Given this list of marker genes ZNF354C, MAP7D1, MORC3, TUT4, ICAM2, NFKBID, SUSD3, AGFG1, EMP3, METTL26, HARBI1, TXNDC9, SESN3, PDLIM5, CSTPP1, ARF6, ARSK, FBXO32, C6orf132, KLF10, B3GALT5, CELF1, TOR3A, RASL11A, PTPRC, PI4K2B, NUDCD1 (NudC domain containing 1), MIB2, MORC1, PRCC, NPM3 (NCBI Gene Id 63295), PLCG1, TPST2, STN1, CDC14A, MSS51, ITGA7, B3GNT2, ZNF565, FAM133B, MEF2D, PLP1, ARRDC2, BAIAP2, COX7A1, JAK1 (NCBI Gene Id 3716), YIPF7, SEPTIN6, MNAT1, UCHL1, AHI1, ZNF260, UCK1, SAMD9L, ZDHHC20, ANKRD28, GPR65, XIRP1, RIOK1, RAD52, HRH2, PLCH1, NXPE3, MOB2, PHOX2A, MXD1, PYCR2, CHL1, SURF1, OAS1, UCP1, DNAAF4, ZNF704, STIM2, VSIR (V-set immunoregulatory receptor), KLHL42, RAMP1, MAPK1, PTPRG, TIFAB, AKAP13, BST2, LIMS4, CTU1, WIPI2, TMEM242, CPNE3, SCO1, PPCDC, TMEM18, ZNF322 (zinc finger protein 322), ABHD11, CDC14B, KLF7, PAK1IP1, ZNF207, ACOX3 (acyl-CoA oxidase 3, pristanoyl), FAM120B, GSPT2, GRIN3A, DNAJC3, NOTCH4, OSBPL5, SLC15A4, SENP7, EPS8, TTLL12, IFNAR1, RRM2B, TP53, TTLL4, DGKH, ERAP1, MORN4, FAM98B, THAP2, MACIR, C1GALT1, HSD17B12, SLC9B1, VAMP4, SELP, FGD5, ZNF141, QTRT2, THAP4, RFESD, NDFIP2, NEK3, KRT222, PDHA2, PLXDC2, STARD6, GLIPR1L2 (GLIPR1 like 2), SQLE, CLUAP1, ABL2, RBL1, SFT2D2 (SFT2 domain containing 2), TMEM50B, PAICS, AIM2, SOCS2, GPRIN3, TBC1D10C, GNB4, PIK3R5, ZDHHC4, CHAT, BCL6, MRPS34, LSP1, KCNK6, GNA11, OSBPL3, ALDH7A1, ECHDC2, NEIL1, AKNA, NHSL2, TES, MOV10, GOLGA7, ZFP36L1, CHD7, SEPHS2, IRF7, CITED2, LRRC8A, CIBAR1, LARP1, MCF2, ITGB2, DEPDC1B, DHRS7, HERPUD1, DKKL1, FLACC1, PNPT1, ERI1, S100A1, OSBPL9, DHX58 (NCBI Gene Id 79132), SLCO3A1, BST1, RAP1GAP2, SS18, WDR45, TTC9C (tetratricopeptide repeat domain 9C), CYTH4, MTSS1, RHBDL3, EPHX4, CEP83-DT, ZBTB11, SFRP2, C5orf34, CENPH, POGK, INSL5, here is a description of the gene set: Genes down-regulated in comparison of Th2 cells versus Th1 cells. species: Homo sapiens Multipotential naïve CD4+ T cells differentiate into distinct lineages including T helper 1 (Th1), Th2, Th17, and inducible T regulatory (iTreg) cells. The remarkable diversity of CD4+ T cells begs the question whether the observed changes reflect terminal differentiation with heritable epigenetic modifications or plasticity in T cell responses. We generated genome-wide histone H3 lysine 4 (H3K4) and lysine 27 (H3K27) trimethylation maps in naïve, Th1, Th2, Th17, iTreg, and natural (n)Treg cells. We found that although modifications of signature cytokine genes (Ifng, Il4, and Il17) partially conform to the expectation of lineage commitment, critical transcription factors such as Tbx21 exhibit a broad spectrum of epigenetic states, consistent with our demonstration of T-bet and IFN-gamma induction in nTreg cells. Our data suggest an epigenetic mechanism underlying the specificity and plasticity of effector and regulatory T cells and also provide a framework for understanding complexity of CD4+ T helper cell differentiation. from publication Wei G, Wei L, Zhu J, Zang C, Hu-Li J, Yao Z, Cui K, Kanno Y, Roh TY, Watford WT, Schones DE, Peng W, Sun HW, Paul WE, O'Shea JJ, Zhao K (PMID 19144320) Human Gene Set: GSE14308_TH2_VS_TH1_DN